Given this list of marker genes Stat2, Btla, Sult1a1, B4galt3, Gatm, Plgrkt, Cmtm6, Aamp, Cflar, Uck2, Mcl1, Reep3, Jtb, Crem, Pex11a, Ocstamp, Cdkn1a, Litaf, Rbm8a, Srgn, S100a6, Slc2a1, Csf2rb, Ifi35, Cdkn2d, Coro2a, Ifitm2, Irf5, Mbd2, Ccnd3, Tmem131l, Mt2, Swap70, Pgam1, Pdcd4, Cox17, Psmb4, Adpgk, Mif4gd, Rnf19b, Ccl5, Gramd2a, Necap2, Bcl2a1b, Fyn, Adam19, Cd38, Cd53, Ddi2, Casp8, Plek, Dock10, Runx1, Rras2, Ier3, Psmd6, Ikbkb, Kmo (NCBI Gene Id 98256), Mrpl20, Sdhc, Fcgr3, Ctss, Jak2, Baz1a, Arhgap26, Ncbp3, Ciita, Gpr141, Atp6ap2, Ptpn1, Zfp703, Cpne2, Slfn2, St6gal1, Marcks, Rap2a, Arfgap3, Socs1, Eif1, Plac8, Mdfic, Rab7, Epsti1, Runx3, Orai1, Atp1a1, Cst3, Adap2, Ciapin1, Spg21, Pde1b, Adam8, Tle3, Tmem131, Arl8b, Plscr1 (NCBI Gene Id 54533), Casp6, Htr7, Asb2, Myd88, Gpr146, Cd274, Plpp1, Adgre5, Arhgap22, Tmed5, Eif5a, Ifitm3, Ifitm1, Hhex, Kctd12 (potassium channel tetramerisation domain containing 12), Cxcl16, Tax1bp1, Sdc4, Casp4, Fchsd2, Rtn4, Rabgap1l, Mllt6, Arrdc4, Ifi205, Man1a, Pfkp, Galnt7, Zfp516, Cd300lf, Slc22a15, Susd6 (NCBI Gene Id 217684), Mkrn1, Cd40, Mtss1, Xbp1, Atox1, Cyrib, Ube2d3, Rab14, Eif6, Bcl2a1a, Pim1, Cytip, Eloc, Tspo, Scimp, Gpr171, Slc30a4, Tgfbi, Tmem38b, Serinc3, Fth1, Basp1, Armc8, Ccdc86, Sri, Bcl3, Lrrc8c, Cox8a, Lims1, Socs3, Mfsd14b, Bcl2l11, Rasa2, Sla, Wnk1, Cbl, Sipa1l3, Fads1, Secisbp2l, Pacsin2, Cyp4f16, Sh3pxd2b, Gca, Chd7, Cxcl9, Gpcpd1, Fcgrt, Fgr, Cidea, Ly75, Plpbp, Fkbp5, Il1b, Prorsd1, Csf2rb2, Ahr (NCBI Gene Id 193333), Srp9, Slc25a38 (NCBI Gene Id 208638), Mrps7, Fnbp1l, Rabep1, Fut8, Atp6v1a, Wfdc17, Nlrp3, Pik3r1, Il18, Ccl17, Ptpn2, Batf3, Gosr2, Oasl2, Stk17b, Tnfrsf13b, Fkbp1a, Gnb4, AA467197 (expressed sequence AA467197), Klf5, Actn1, Nrros, Snx8, Trpv2, Dnase1l3, Rin3, Apobec3, Atp13a3, Hdlbp, Bin2, Tbc1d8, Prkcd, Ch25h, Scand1, Tes, Pnpla2, Flot1, Metrnl, Riok3, Cish, Enah, Lfng, Ddit4, Itgae, Dnajc21, Pdcd1lg2, Srsf5, Ndufb11, Clec2d, Tmbim6, Trim30a, Rara, Stk24, Ms4a4c, Lgmn, Ms4a6d, Tm9sf2, Pts, Plet1, Atp8a1, Nckap1l, Flnb, Lrrk1, Pnp, Eps8, Malt1, Atp1b3, Mt1, Snap23, Fabp5, Cd300a, Serpina3g, Cd2ap, Spint1, Osbpl3, Timm10b, Syngr2, Ewsr1, Krcc1, Rbm26, Gprc5c, Glipr2, Pkib, Irf2bp2, Rap2b, Tspan13, Hfe, Ranbp2, Pttg1ip, Cdk2ap2, Tnfaip3, Rbm47, Iscu, Bcl2a1d, Slc33a1, Pak1ip1 (PAK1 interacting protein 1), Ccr7, Foxn3 (NCBI Gene Id 71375), Picalm, Fh1, Bbx, Id2, Ccnd2, Bhlhe40, Lmnb1, Kdm6b, H2-DMb2, Zdhhc5, here is a description of the gene set: from publication Cui A, Huang T, Li S, Ma A, Pérez JL, Sander C, Keskin DB, Wu CJ, Fraenkel E, Hacohen N (PMID 38057668) studied in species Mus musculus Genes positively differentially expressed in cell type: cDC1 (conventional dendritic cell type 1) upon treatment with cytokine: IL-1β in mouse lymph nodes in vivo. Cytokines mediate cell-cell communication in the immune system and represent important therapeutic targets. A myriad of studies have highlighted their central role in immune function, yet we lack a global view of the cellular responses of each immune cell type to each cytokine. To address this gap, the authors created the Immune Dictionary, a compendium of single-cell transcriptomic profiles of more than 17 immune cell types in response to each of 86 cytokines (>1,400 cytokine-cell type combinations) in mouse lymph nodes in vivo. A cytokine-centric view of the dictionary revealed that most cytokines induce highly cell-type-specific responses. For example, the inflammatory cytokine interleukin-1β induces distinct gene programmes in almost every cell type. A cell-type-centric view of the dictionary identified more than 66 cytokine-driven cellular polarization states across immune cell types, including previously uncharacterized states such as an interleukin-18-induced polyfunctional natural killer cell state. Mouse Gene Set: CUI_CDC1_IL1B_RESPONSE_UP